The following is a description of a gene set: Human Gene Set: HP_ABNORMAL_CIRCULATING_FATTY_ACID_ANION_CONCENTRATION studied in species Homo sapiens Abnormal circulating fatty-acid anion concentration Any deviation from the normal concentration of a fatty acid anion in the blood circulation., and this is the list of marker genes: ATAD1, IVD, SCO1, ABCD4, NDUFAF6, HMGCL, COL7A1 (NCBI Gene Id 1294), SLC22A5, NDUFA2, ACADVL, ETHE1, DNM1L, EHHADH, ACADS, HADHA, MMACHC, SLC34A1, GATM, TANGO2, COX16, PGM2L1, MCEE, CTNS, CPT2, ACAD9, SLC25A20, MCCC2, PEX26, OBSCN, TRMU, NADK2, HADH, GCDH (glutaryl-CoA dehydrogenase), ACADM, ACAD8, MT-TE, MMP1, LYRM7, MMAB, DLD, LMBRD1, SLC52A1